The following is a description of a gene set: We combined large-scale mRNA expression analysis and gene mapping to identify genes and loci that control hematopoietic stem cell (HSC) function. We measured mRNA expression levels in purified HSCs isolated from a panel of densely genotyped recombinant inbred mouse strains. We mapped quantitative trait loci (QTLs) associated with variation in expression of thousands of transcripts. By comparing the physical transcript position with the location of the controlling QTL, we identified polymorphic cis-acting stem cell genes. We also identified multiple trans-acting control loci that modify expression of large numbers of genes. These groups of coregulated transcripts identify pathways that specify variation in stem cells. We illustrate this concept with the identification of candidate genes involved with HSC turnover. We compared expression QTLs in HSCs and brain from the same mice and identified both shared and tissue-specific QTLs. Our data are accessible through WebQTL, a web-based interface that allows custom genetic linkage analysis and identification of coregulated transcripts. species: Mus musculus Human Gene Set: BYSTRYKH_HEMATOPOIESIS_STEM_CELL_FLI1 Genes whose expression is coregulated with that of FLI1 in hematopoietic stem cells (HSC). from publication Bystrykh L, Weersing E, Dontje B, Sutton S, Pletcher MT, Wiltshire T, Su AI, Vellenga E, Wang J, Manly KF, Lu L, Chesler EJ, Alberts R, Jansen RC, Williams RW, Cooke MP, de Haan G (PMID 15711547), and this is the list of marker genes: TAP2, IFT27 (NCBI Gene Id 11020), IL1RL1, DBF4, HIC1, RAB5B, MYF6, FANCG